Given this list of marker genes Akt2, Banp, Pou4f2, Trp53, Ppp1r13b, Ppp1r13l, Akt3, Phf20, Zfp385a, Pou4f1, Trp63, Akt1, Trp53bp2, Trp73 (NCBI Gene Id 22062), here is a description of the gene set: Regulation of TP53 Activity through Association with Co-factors species: Mus musculus Mouse Gene Set: REACTOME_REGULATION_OF_TP53_ACTIVITY_THROUGH_ASSOCIATION_WITH_CO_FACTORS